The following is a description of a gene set: from publication Yevshin I, Sharipov R, Kolmykov S, Kondrakhin Y, Kolpakov F (PMID 30445619) Genes containing one or more binding sites for (Gli2) in their promoter regions (TSS -1000,+100 bp) as identified by GTRD version 20.06 ChIP-seq harmonization. species: Mus musculus Mouse Gene Set: GLI2_TARGET_GENES, and this is the list of marker genes: Or2q1, Tex14, Or5t9, Ddx25, Phc2, Gid8, Slc22a21, Nrdc (NCBI Gene Id 76534), Txnl4a, Abcd4, Zfp142, Carmil1, Nyap1 (NCBI Gene Id 243300), Tnip1, Kras, Rny1, Bcl2, Fam234a, 4933437G19Rik, 1700057H15Rik, Ppp2r5d, Rpgrip1, Myocd, Rnf170, Id3, Zfp148, Gtf2h3, Svopl, Krtap26-1, Rnf146, Id2, Gm13889, Atg4b, Psd2, Cyyr1, Prrc1, Efs, Rgl1, Ppp2r5a, Tg, Rps29, Atp13a5, Smad9, Nsf, Arl14ep, A430057M04Rik, Arhgap44, Fam222b, Cep131, Hdac6, Gm35106 (NCBI Gene Id 115489689), Ephb3, Limk2, Gm16794, Zfp641, Traj2, Gm15322, Tle3, Orc3, Eeig1, Mrpl53, 9130213A22Rik, Crem, Zbtb42, Vps50, mt-Rnr2, Rbm17, Pafah1b1, H4c16, Map2k7, Entpd6 (NCBI Gene Id 72561), Oasl1, Kif18a, Snx17, Zfp277, Sestd1, Vmn1r-ps85, mt-Nd6, Samd13, Pkhd1, 4930545L23Rik, Gm6746, Irs1, Exoc1l, Ssbp2, Nlgn2, Mlec, B4galt3, Itih6, Zkscan3, B3glct, Cmah, Mir3960, Atf7, Ltbp1, Gm13600, Sacm1l, Dynll1, Gm42614, Med12, Ldb1, Tbc1d24, Rgs22, Ogg1, Nprl3, Fnbp4, Trp63, Cfap68, Fbxl12, Inpp4b, Raph1, B4gat1, Rnf220, Blcap, Slc43a2 (solute carrier family 43, member 2), Pxylp1, Snord45c, Fn1, Gnb2, Ntaq1, Npsr1, Atp13a4, Wdr25, Rictor, Bicdl1, Vangl1, Selenof, Or5p59, Chil5, Rab6a (NCBI Gene Id 19346), Iigp1c, Or10al6, Has2, mt-Te, Mir99ahg (Mir99a and Mirlet7c-1 host gene (non-protein coding)), Eva1c, Mir210, Krt31, Cnnm2, 9130410C08Rik, Or8g20, Fam241b (NCBI Gene Id 69894), Gm22850, Poldip3, Polr2a, Gabbr1, Tmem119, Kntc1, Lipt2, Agbl5, Myh14, Neo1, Gm18717 (predicted gene, 18717), Gpn3, Gm16170, Gm25177, Echs1, Nol4, Mageb3, Smg6, Vps18, Nlgn3 (NCBI Gene Id 245537), Polr1h, Ccnjl, Gm12551, Skp2, Ddx55, Or8k28, H2ac5-ps, Gm23010, Tpbg, Tcaf2, Mir680-1, G530011O06Rikx, mt-Ti, Ube2h, Prmt5, Pafah1b3, Mynn, mt-Tp, Slc16a9, Arhgef15, Gm2497, Igkv1-135, 0610038B21Rik, Nr4a3, Asb4, Lmna, Mthfr, Gm31243, 1700086O06Rik, Gm12366, Rab11a, Dtx1, Lrrc46, Zfp788, Hook1, Slc36a1, Tfip11, Sgf29, Gm24202, Nlrp9c, Pkdcc, Zhx3, Adamtsl1, Dtwd1, Gm18382, Npepps, Mios, Sec61bl, Phldb3, Dhx37, Akr1a1, Nfe2l1 (nuclear factor, erythroid derived 2,-like 1), Gm23248, Exo1, Mvb12b, 2410003L11Rik, Or10ag52, Edem3, Gm15564, Amz2, Klhl5, 9230111E07Rik, Gm24978, Rbm15b, Or4a70, Plxna4, Hsh2d, Fbxo31, Luc7l2, Knl1, Bcl11a, Pnpla8, Septin2, Ppp1cb, Rbp4, Mettl18, Bcam, Or2b6, Slc12a4, Gm9419, Calcrl, Smurf1, Gm26012 (predicted gene, 26012), Nkx2-9, Col7a1, Ntmt2 (N-terminal Xaa-Pro-Lys N-methyltransferase 2), Lrrcc1, Nae1, Dpy19l1, Fcor, Slc10a3 (solute carrier family 10 (sodium/bile acid cotransporter family), member 3), Abat, Abcb1b, Lyrm1, Fbln1, mt-Tq (NCBI Gene Id 17740), Hdgf, Gm23674, Eef1akmt1, Dock4, Draxin, Sqor, Camk2d, Clasp2, Gm17215, Trim71, Tph2, Esr1, Alg13, Gm30735, Snapc3, Mcm4, Kif4, Mrpl23, Col28a1, Mir2861, Trappc2, Ckb, Xrn1, Pcbp1, Kat6a, Prss22, Dalrd3, Polr1b, Mars1, Gm12439, Doc2a, Foxo1, Gm10766, Pomgnt1, Mrps9, Mat2a, Itgav, 4930507D10Rik, Faap20, Arhgef16, Gm21978, Dnajc16, Stx18, Gm17944, Btbd9, Gm9392, Map4k4, Otogl, Jmy, Mdc1, Slc13a1, Acp6, Tulp4, Vmn2r-ps66, Phf23, Dusp16, Gm24948, Nsun6, Camta1, P2rx3, Neurog1, Zfp518b, Pnkp, Mtcl2, Tia1, Foxp1, Slc38a2, Dram2, Batf3, mt-Tl1, Gpr35, Gm12199, Gnb4, Usp16, Cry2, Ripor2, Zfp583, Mir207, Cdc123, Shroom3, Lasp1, Bspry, Bub1b, Trim33, Gm26901, Gm10531, Skil, Ptprn (protein tyrosine phosphatase receptor type N), Plekhj1, Hlf, Brd2, Gm9972, Gm10440, Ccdc107, Pparg, Ranbp1, Mocs1, Tigd5, Map3k9, Agrn, H2ac6, Rnh1, Or51b6b, Gm22523, Rdm1, Hipk1, Srebf1, Lrp3, Gm10637, Il15ra, Gm26330, Pax6, D330023K18Rik, Gm4956, Reln, Arhgap31, Cipc, Khsrp, Rbm5, Fhl3, Mrps33, Tti2, Smarcc2, Mycn, Gm13415, Gm128, Pigq, Igkv16-104, Vsnl1, Abca13, Dap3, Lta4h, Tmem64, Phlda1, Cfap100, App, Slc5a9, Atn1, Baz1b, Gm9874, Ikbkg, Ap4m1, Fam3a, Pemt, Rab5b, Slc22a23, H4c8, A930032L01Rik, Gnl1, Hey1, Ttbk2, Mphosph8, Atrnl1, Zbtb4, Gm11523, Mtrf1, Slc35f5, Sema6a, Ipmk, Gm23497, Cnr1, Zfp523 (NCBI Gene Id 224656), Necab2, Mir6237, Rab11fip4, Sgms2, Hyal4, Pan3, Runx1t1 (RUNX1 translocation partner 1), Stxbp5l, Itpr3, Cfap20dc, Gm22534, Ncbp3, Cacnb2, Trbv8, Stk11ip, Prkdc, Fbxo10, Atxn2, Ddx19a, Epb41l4b, Cdh12, Lpcat3, Lgi1, Erc1 (ELKS/RAB6-interacting/CAST family member 1), Flicr, Odad4, Spata31e2, Id1, Rbm25, Mtss2, Atp5f1d, Polr1has, Cdc73, Whrn, Pik3cg, Ccr9, Abhd2, Zkscan2, Tmem62, Marchf8, Ndel1, Gm15612, Gm15246, Ino80d, Mir1191b, Gm22139, Msl2, Sox4, Ski, Pcif1, Oip5, Thrap3, Klhl28, Gm16876, Rasgef1b, Dleu2, Vmn1r196, Mir467f, Gpr107, Myh2, Dusp26, Gtf2a1, Eif4g2, Trim39, Tmem63b, Pold1, Iglc3 (immunoglobulin lambda constant 3), Atp10a, Bcl2l1, Or4c113, Psmb3, Steap1, Gm13360, Gm12679, Tomm34, Rnf115, Bdh1 (NCBI Gene Id 71911), Prame62, Arhgef2, Phospho1, Atg4a, Trmt112-ps1, mt-Tv, P2ry1 (NCBI Gene Id 18441), Aak1, Nabp2, Timm10, Tead1, Tax1bp1, Rasal2, Grxcr2, Rps27l, Ntng1, Adam17, Gm25970, Nek9, St6gal1, 1700003M07Rik, Prr3, Nxt2, Pam, Ilf2, Man1a2, Hdac5, Prmt7, mt-Nd4l, Srpk2, Gimd1, Tagln2, Gm15581, Polr3e, Sf3a2, Opn1sw, Hrob, Cpsf4l, Mroh2a, Shkbp1 (NCBI Gene Id 192192), Dtd1, Gm16318, Ebag9, Mir6236, Kmt2a, Gm12752, Tent4a, 4930518I15Rik, Mpz, Gm23754, Prps2, Hyal1, Tmem256, Sct, Dhx40, Ftsj3, Fam171a1, Mrps18a, Gm22743, Lsm4, Dnajc7, Cp (NCBI Gene Id 51906), Mn1, Mast2, Prdm11, 1700001O22Rik, Kdelr3, Npm1 (NCBI Gene Id 18148), Hspe1, Slc7a6os, Fancc, Or5d38, Ndufs7, Jmjd8, 2810039B14Rik, Atg101, Hhipl1 (NCBI Gene Id 72015), Lss, Cxxc5, Gm25977, Mbd3l1, Gm9696 (NCBI Gene Id 676914), Ctdspl2, Eif4a1, Msantd7, Firrm, Asb3, Isca1, Spef1, Hsp90aa1 (NCBI Gene Id 15524), Akt2, Pln, Gm15706 (predicted gene 15706), Psmd11 (NCBI Gene Id 97704), Rpl7l1, Renbp, Maz, 4930447A16Rik, Bcl7c, 2410021H03Rik, Gm8357, Gm11541 (NCBI Gene Id 432589), Gm24789, Fam107b, Vmn1r197, Chd9 (chromodomain helicase DNA binding protein 9), Slc41a1, Gm23441, Supt6, Map4, Gm23793, Or10aa3, Gm27198 (predicted gene 27198), Anks3, Nxf1, Dennd4b, Tas2r125, Vmn2r124, Ift46, Tlk1, Ppp6c, Park7, Usp37, Gar1, Vmn2r67, Calm3, Tgfb1, Mrpl14, Zfp446, mt-Nd5, Gm23838, N4bp2l2, Grn, Mir199b, C1galt1, Zfp950, Egfem1, Yif1a, Tnpo3, Gm12019, Lrrc8c, Mir8120, Per2, Gm23926, Pfdn5, Cdk12 (NCBI Gene Id 69131), Mir195b, Strn4, Ercc1, Nav2, Dock9, Or1e23, Mir28c, Gm10544, Dot1l, Cog2, Mkx, Parp2, 9330162012Rik, Fbrsl1, Ptpmt1, Gm18747, Eda, Cacng2, Acvrl1, Ap1g2, Serpine2, Rpl18 (NCBI Gene Id 19899), Acacb, 1700094M23Rik, Mex3a, Nell2, Gm14267 (NCBI Gene Id 383773), Mapk14, Pdap1, Gm22588, Adam5, Ercc6l2, Ric1, 4930477E14Rik, Nsmaf, Psmd5, Traf3ip2, Iffo2, Or6c206, Znrf1, Ccr1, Tmem39a, Ddx5 (DEAD box helicase 5), Gm22589, Satb1, Seh1l, 5530400K19Rik, Mrpl32, Stx5a, Zmynd11, Eef2kmt, Or8b3, Frem1, Dhrs3 (dehydrogenase/reductase 3), Rps6kb2, Rusc1, Pcdhb16, Ralgds, Nectin3, Gm28153, Afg2a, Tatdn3 (TatD DNase domain containing 3), Rps15, Gm12387, Ube2k, Myo9a, Or7h8, Elf2, A930007I19Rik, Mir1983, Cep120, Gpr153, Gm13378, Noxred1, Chsy1, Mettl26, Fbxo30, Ddit4, Smox, Mtmr14, Trbv9, Gm22363, Chek2, 1700064H15Rik, Frat1, Slc6a2, Gm17491, Gm15860, Myo15b, Stat3, Sat2 (spermidine/spermine N1-acetyl transferase 2), Zfp998, Arhgap6 (NCBI Gene Id 270682), Sfxn1, Casp2, Hmgn2, Hmga2, Ulk3, Tbpl1, Agbl4 (ATP/GTP binding protein-like 4), Mrps18b, Gm15795, Clec12a, Gm28900, Dimt1, Nsrp1, Esd, Tceal3, Gm11400, Med16, Cage1, Mir8105, Mycbpap, Rcor3, C920006O11Rik, Mad2l2, Gm12010, Togaram1, Igf1, Dag1, Rasal1, Phldb2, Trp53bp1, Ube2e1, Aldh16a1, Gm12526, Vmn1r74, Map3k1, Washc2, Gm24162, Celrr, Ptch1, Snord118, C230035I16Rik, Fpr-rs7, Isoc2b, Slc27a2, Rxra, Emid1, Stard7, Sfrp1, St8sia1, Glb1l, Elp6, Tnfrsf9, Mfap4, Twf2, Cox7a2, Vmn2r19, Pah, Arhgap33, Dock10, 4930448I18Rik, Rpl34, 1600020E01Rik, Trmt61b, Gm11359, Mpp1, Nnat, Tnfrsf11a, Mid1, Lgals1, mt-Nd4, Itpr2, Entpd7, Chmp3, Ano5, Cenpu, Dlg1, Plekhg2, Olfm3, E2f7, Sirt1, Mir6373, Gm12770, Ppil6, Dio3, Smpd2, BC006965, Ttc28, Iqsec1, Tmem51os1 (Tmem51 opposite strand 1), Unc13a, Gtf3c6, Ctsa, Wbp4, Nr2e1, 1700016P03Rik (NCBI Gene Id 75542), Zfp988, Pth1r, Teddm2, Cep104, Speer4d, Gm5334, Rps19-ps8, mt-Nd1, Pcmtd1, Ccdc30, Pja1, Tln2, 4933439C10Rik, mt-Th, Itsn2, Mfap3l, Gm13742, Meaf6, Stk35, Lca5l, Polg, Snx14, Zbtb14, Zfp46, Banp, 2410002F23Rik, Rps10, Tbc1d16, Efna2, Gm26559, Gm4419, Ptpn14, Anxa6, Cntn6, Gtf2ird1, Mb21d2, Mycbp2, Qtrt2, Gm11399, Nek4, Gm6283, Gm14064, Atpaf1, H2bc3, Rab21, Cdc25b, Or4c11c (NCBI Gene Id 404486), Nr2c2, Clcn6, Ugt1a5, Diras1, Scfd2, Gm19265, Samm50, Rny3, Gm11527, Rexo5, Myl12b, Snai1, Kcnip4, Arsk, 4921507G05Rik, Dvl3, Polq, Uaca, Wbp1l, Tomm40l, Gm22220, Zfyve21, Arfgef1, mt-Tt, Gm7442 (NCBI Gene Id 675511), Pnn, Rpl31 (NCBI Gene Id 114641), 4930511A02Rik, Gramd2a, Ube2z, Ntn5, H1f2, Trim24, Gm24173, Sox9, Hc, 1700049L16Rik, Or4c115, Map1b, Zhx1, Kcnb2, Pkn2, Arl6, L3mbtl2, Sox2ot, Zfp982, Gm7616, Akap1, Eef2k, Bcl7a, Gm26654, Cfap144, Cstad, Trmt2a, Gm14488, Pkn1, mt-Nd3, Kctd2, Slit3, Pld2, Senp8, Malat1, Mir6392, Hmg20a, Polr3c, Aifm2, Maneal (NCBI Gene Id 215090), Lpcat1, Otx2os1, Fignl2, Or8j3, Pcdh9, mt-Tf, Mir212, Atp2c1, Naa10, Tnk2, Hsd17b8, Ppm1m, Sclt1, Btf3-ps4, Romo1, Kat14, Khk, Trp53i11, Or8c8, A130023I24Rik, mt-Ts2, Mcc, Arhgef1, mt-Rnr1, H2ac18, Utp23, Polr2f, Foxn3, Kif11, Msrb2, Scnn1b, Sfi1, Lrrc8d, Usp45, Aloxe3, Rbms1, Nubp1, Foxl1, Or1l4b, 1500026H17Rik, Ptpn12, Gm26335, Taf8, Aopep, Gm15723, Ighv1-67, Hsp90ab1 (NCBI Gene Id 98078), Ccne2, Pskh1, Tfap4 (transcription factor AP4), Sft2d3, Hook3, Ccdc142os, Rcn3, Pip4p2, Or5b107, Cyp4a14, Snhg7os, Zkscan17, Gm2199, Myl6, Pheta1, Scd1, Zw10 (NCBI Gene Id 76189), Mucl2, H1f3, 1700019P21Rik, Snora17, Ensa, Atp5pd, Ahctf1, Ang, Tomm70a, Ppil4, Gm5127, Or5m9, Cers5, Cd24a (CD24a antigen), Agtpbp1, Hck (NCBI Gene Id 99093), Polr3g, Or5t18, Fam161a, Kdsr, Bcl2l11, Calm1, Kat6b, Usp2, Etl4, Cdnf (NCBI Gene Id 227526), Gm13855, Dido1, Ppp1r3f, Blmh, AV039307, Pcbp2, Mcf2, Mrpl17, 9530080O11Rik, Cd300c, Mrpl10, Rangrf, Rac3 (NCBI Gene Id 170758), Opcml, Trhde, Mrpl12, Stxbp6, C2cd3, Dcun1d3, Grm7, Rabggtb, Igkv4-74, Tmcc3, Dnase1l3, Gm23987, Myo18a, Shmt2 (serine hydroxymethyltransferase 2 (mitochondrial)), Sowaha, Gm26679, Psmd10, Rnase4, Mrpl23-ps1, Scarna2, Rpia, Dnm3, Gm25541, Senp1, Sema6d, Prkacb, 1700006A11Rik, Akap13, Zscan12 (NCBI Gene Id 80418), Tmem98, Stat6, Hnrnpu, Rab3ip, Or14a257, Pakap, Bcs1l, Cep112, Mblac2, Prpf3, Nkiras2, Nr2f1, Il1bos, Grcc10, mt-Tg, Slc12a5, Cep95, Mical1, Cept1, Xrcc3, Mpnd, Tmem51, Prob1, Scgb1c1, 4933427E13Rik, Tut4, Glyat, Col11a1, Areg, Gm36448, Flvcr1, Etohd2, Gm16133, Prkci, Crisp3, Abi2, Alyref2, Crtc3, Camk2g, Rab34, Tmprss7, Nfic, Zfp36l1, mt-Tl2, Htatsf1, Ggct, Zdhhc12, Slc29a1, Kmt2d, Fam219a, Mtrf1l, Or5ar1, Epyc, D7Ertd443e, BB557941, Pus3, Asph, U2surp, Capza2, Kdm4c, Rmrp, Acot12 (acyl-CoA thioesterase 12), Sik3 (NCBI Gene Id 77161), St3gal3, Gm25631, Wars1, Gm11205, Gipc2, Gm3436, Sbds, Tbl1xr1 (NCBI Gene Id 99912), Gm25064, Zic4, Ash1l, St6gal2, Sigmar1, Gm25552, Rnasek (NCBI Gene Id 66944), Gm31925, Zfp276, Sergef, Ighv1-84 (NCBI Gene Id 434609), Cacng5, Dhx36, C1qbp, 1700096K18Rik, Gm11872, Duxf1, Ghrh, Ccdc63 (coiled-coil domain containing 63), Mir3154, Ktn1, Plb1, Mir100hg, R3hcc1, Evc2, Nnt, Rhbdl3, Ogfod3, Gm6215, Nudt6, Prpf40a, BC046401, Mak, Syncrip, Lin28a, Nnmt, 6820431F20Rik, mt-Cytb, Pygo2, Ergic2, Serpinc1, Cuedc1, Smpd3, Inf2, Inpp5k, Thap4, Cetn3, Slc25a40, Gm13421, Hs2st1, Cdkn2aipnl, Gm6116, Gpd1l, Sp5, Extl3, 1700010K23Rik, 9030622O22Rik, Arl5b, Hfm1, Rbm15, mt-Co1, Zfp36l2, A230083N12Rik, Rps8, Speer4cos, Ckap5, Rere, Dpyd (NCBI Gene Id 99586), Mir3073a, Fgf5, Vmn2r-ps68, Dnmt3a, Gm40190, Alcam, Phactr4, Egln1, Hpca, Ighv3-8, Dleu7, Gm26802, Coil, Fam222a, 1700042G15Rik, Ddx39b (DEAD box helicase 39b), Gm22863, Mcl1, Gm15464, Madd, Ywhaq, Bach2, Mir8101, Septin7, Eef1d (NCBI Gene Id 76576), Fmc1, Fgd3, Eaf2, Mok, Evi5l, Grik2, Mir3083, Bud31, Postn, Gm43838, Rbmx, Or9i15-ps1, Atp6v1e1, Rsrc2, Eif4enif1, Dhcr24, Pcnp, Mcm7, Tbc1d1, Frmpd1, Cldnd1, Zeb1, Vmn2r7, Vsig10, Pvrig-ps, Commd7, Vmn2r-ps11, Rgma, Hspd1, Gm22661, Papolb, Lnpep, Wfikkn2, H2bc18, Ncoa6, Cibar2 (NCBI Gene Id 436062), Umod, Adamts1, Trak2, Clcn2, Crebzf, Huwe1, Vmn2r8, Vstm2l, Foxj1, Lhb, Lamp5, Azin1, Nr2e3, 4930577N17Rik, Met, Wtap, Ctnna3, Slc35f1, Nutm1, Stat5b, Cdc42bpa, Mmp12, Smok2a, Fgf18, Syt7, Sh3pxd2b, Kdm1a, Arhgap24, Gm11816, Or6c68, Virma, Ppid, Gramd1b, Gm9951, Lrig1, Egr2 (early growth response 2), 7530428D23Rik, Ugp2, Gm11292, Gcat, Zfp707, Scn2a, Zmiz1, Gm24641, Ttc12, Trpc7, Dnaja1, Hdlbp, Chtf18, Kif6, Ccdc134 (coiled-coil domain containing 134), Osbp, Ptbp1, Spred2, B230307C23Rik, Nusap1, Pura, Lyrm7, Txndc17, Tnpo1, Gm10655, Gm24288, 9230117E06Rik, Zfp532, Gabrb3, Vdac3-ps1, Tmem87b, 4930535O05Rik, Gas7, Stx11, Gm5268, Gm15577, Ubl5 (NCBI Gene Id 66177), A230006K03Rik, Ifnar1, Ppp4r1, Thrb, Shf, Gm5445, Dbndd2, Gm5432, Slc25a23, Plch1, Hspa8, Gpt2, Gpr85, Tcf4 (NCBI Gene Id 67762), Zfp395, Cfap418, Dnm1, Snord55, Ptch2, Ssrp1, Mcm3ap, Aasdh, Por, Eya4 (NCBI Gene Id 319558), 2610316D01Rik, Tsc22d2, Med12l (NCBI Gene Id 99835), Vps9d1, Gm15270, Gigyf2, Cenpi, Mir219a-1, Celf4, Rc3h1, Elapor2, Gpsm2, Prl6a1, Cdk9, Cdk4, C030010L15Rik, Gm15038, Pim1, Hnrnpdl, Ppp6r3, Nfatc2ip, Heyl (NCBI Gene Id 56198), Prkag2, Hexd, Gm12192, Gm13830, Prrg4, Gm5135, Pik3r3, Hprt1, Snord64, Tmem94, Acsl1, Gadd45b, Gm25760, Zfp267, Abtb1, Ndufs8, Bcas3, Akirin1, Gm14661, Trip6, mt-Tr, Abcg2, Gm10143, Naa35, Cdan1, Bccip, Rxylt1, Zfp787, Car7, Cenatac, Rapgef4os2, Iglc4, Has2os, Tmem45a, Ybx2, Flad1, Scmh1, Usp9x, Naa30, Gal, Luc7l3, Irs2, Glul, Csgalnact2, Zfp426, A830082K12Rik, Slc5a5, Zc3h7b, Gm26327, Neurl1a, Celf2, Epo, Acsl4, Cds2, Rnu7, Dcaf12l1, Igkv19-93, Ankrd44, 1700039M10Rik, Sema4d, Gne, Rfx2, Otud6b, Ociad1 (OCIA domain containing 1), Vmn2r24, Alg9 (ALG9 alpha-1,2-mannosyltransferase), Bhlhe41, Gm14486 (predicted gene 14486), Ssu72, Gm7309, Smchd1, Dpp9, Gnai2, Smad7, Afdn, Ncor2, Tsga13, Eif2b4, Sphk2, Cyp2c38, 2610306M01Rik, Septin9, Appl2, Prokr2, Col2a1, 4930595D18Rik, Lrrc7, Fndc3a, Gprin1, Aim2, Mtus2, mt-Tw, Slc25a53